The following is a description of a gene set: Mouse Gene Set: GOBP_NEGATIVE_REGULATION_OF_LYASE_ACTIVITY Any process that stops or reduces the rate of lyase activity, the catalysis of the cleavage of C-C, C-O, C-N and other bonds by other means than by hydrolysis or oxidation, or conversely adding a group to a double bond. species: Mus musculus, and this is the list of marker genes: Akap5, Palm, Rd3, Drd2, Mtrr, Adgrv1, Phpt1